The following is a description of a gene set: part of: Defects in cobalamin (B12) metabolism studied in species Homo sapiens Reactome Pathway: Defective CUBN causes MGA1 Defects in the CUBN gene cause recessive hereditary megaloblastic anemia 1 (RH-MGA1 aka MGA1 Finnish type or Imerslund-Grasbeck syndrome, I-GS; MIM:261100). The Finnish cases described by Grasbeck et al. were caused by defects in CUBN. The resultant malabsorption of Cbl (cobalamin, vitamin B12) leads to impaired B12-dependent folate metabolism and ultimately impaired thymine synthesis and DNA replication., and this is the list of marker genes: CUBN, AMN, CBLIF